The following is a description of a gene set: species: Mus musculus The progression of muscle tissue over time, from its initial formation to its mature state. Muscle tissue is a contractile tissue made up of actin and myosin fibers. Mouse Gene Set: GOBP_MUSCLE_TISSUE_DEVELOPMENT, and this is the list of marker genes: Cdk5, Myl7, Srf, Foxn2, Nkx2-5, S100b, Mir669a-10, Gpx1, Ephb1, Tbx5, Dsp, Pax3, Bmp10, Nr2f2, Hivep3, Pitx1, S1pr1, Pou4f1, Vgll4, Creb1, Lox, Pak1, Mir675, Bin3, Egln1, Ddx39b, Gata6, Zfp418, Ctdp1, Pdlim5, Itga8, Sema3c, Cntnap1, Speg, Cav1 (NCBI Gene Id 12389), Ccnt2, Pin1rt1, Wnt2, Adrb1, Pmp22, Mybpc3, Ttn, Smad4, Alpk3, Fgfr2, Fes, Barx2, Nrg1, Agtr2 (angiotensin II receptor, type 2), Jarid2, Fadd, Adamts9, Tsc1, Gata4, Gpcpd1, Boc, Mylpf, Hdac2, Srpk3, Rbm10, Ero1a, Ppp3ca, Parp2, Myoz1, Isl1, Ube4b, Twist1, Igf1, Myc, Gm2990, Angpt1, Vegfa, Megf10, Tbx2, Nkx2-6, Snw1, Nrap, Rara, Vax1, Adprhl1, Yap1, Hlx, Myod1, Dll1, Maml1, Mir669a-6, Fgf20, Bves, Hspa8, Col19a1, Eya1, Cops2, Hottip, Scx, Usp2, Zbtb18, Rgs2, Xirp1, Mbd2, 2810429I04Rik, Cited2, Maff, Fgf2, Sorbs2, Foxp1, Pdgfrb, Mir669a-8, Lncpint, Uqcc2, Itgb1, Shh, Klk1b1 (kallikrein 1-related peptidase b1), Tnn, Fosl2, Usp19, Kat2a, Myoz2, Klhl40, Zfp689, Nr3c1, Ddx17, Calr, Myh7, Vamp5, Tafazzin, Kcnk2, Cav3, Ankrd33, Hamp, Trip10, Gpc1, Gata5, Aldh1a2, Yy1, Bmp7, Xk, Rhoa, Dipk2a, Stra6, Fdps, Adrb2, Emd, Hsd17b1, Synb, Hey2, Dmrta2, Smad7, Tenm4, Tgfb2, Greb1l, Prox1 (NCBI Gene Id 320240), Bvht, Col11a1, Myl6, Pim1, Mir208a, Ndufv2, Rcan1, Rxra, Ccnd2, Phox2b, Ly6e, Hoxd9, Fhod3, Ski, Klhl41, Bmp5, Sgcb, Acvr1, Sav1, Egr2, Heg1, Sox6, Arid2, Tpm1, Ryr2, Heyl, Gm34220, Mir143, Dicer1, Sgcg, Mapk1, Ncam1, Vgll2, Crhr2, Ppif, Cby1, Asb2, Large1, Arrb2, Rxrb, Bcl9, Chd7, Rgs4, Rpl3l, Bmp4, Cdon (cell adhesion molecule-related/down-regulated by oncogenes), Prkg1, Tbx3, Fgf3, Ctcf, Acta1, Mbnl1, Eln, Klf5, Popdc3, Gtf3c5, Mir669a-3, Tbx18, Tcf7l2, Nprl3, Selenon, Mir669a-5, Cdc42, Myh10, Efnb2, Bmpr2 (NCBI Gene Id 98751), Foxp2, Ankrd1, Zfpm2, Fktn, Gja5, Svil, Mir669a-7, Bdnf, Wnt10b, Hamp2, Stac3, Col3a1, Pi16, Pten, Mtor, Ankrd2, Myh11, Actn2, Prkar1a, Fgf1, Grem1, Tnnc1, Rb1, Tnni1, Atg5, Hdac3, Abl1, Cenpf, Foxc1, Hand2, Kat8, Atg7, Nf1, Med1 (mediator complex subunit 1), Rbpj, G6pd2, Cyp26b1, Smyd1, Csrp2, Chrnd, Ryr1, Slc8a1, Met, Wt1, Pkp2, Camk2d, Flnb, Hspg2, Tnni3, Asnsd1, Col14a1, Tgfbr3, Jph2, Fgfr1 (fibroblast growth factor receptor 1), Tgfb1, Mesp1, G6pdx, Shox2, Actc1, Msc, Mstn, Six1, Lemd3, Tll2, Id2, Zmpste24, Gsk3a, Mef2c, Hey1, Myf6, Nfix, Norad, Psma6, Mir669a-1, Tnnt2, Rtl1, Zic3, Prkaa1, Mecp2, Irx3, Rbm24, Foxl2, Rbfox1 (NCBI Gene Id 58862), Efemp2, Atf3, Pgm5, Egr1, Nr1d2, Ang2, Tgfbr2, Prmt1, Frs2, Skil, Nog, Med20, Ednra, Neurl1a, Dlg1, Myl2, Ppp3cb, Nr4a1, Tbx20, Lmna, Bmal1, Myhas (myosin heavy chain gene antisense RNA), Csrp1, Myh6, Sirt6, Gli1, Rbp4, P2rx2, Cacybp, Agt, Tbx1, Mir133a-1, Pitx2, Nox4, Bmp2, Dyrk1a, Myocd, Sox9, Myom1, Osr1, Epo, Chrna1 (NCBI Gene Id 99038), Mir214, Sirt2, Pln, Fbxo22, Ptcd2 (pentatricopeptide repeat domain 2), Bcl9l, Myl6b, Hlf, Akirin1, Acadm, Btg2, Spg11, Myf5, Dll4, Sgcd, Tiparp, Casp8, Mapk14, Hand1, Ift88, Nln, Epor, Nebl, Sirt1, Slc25a4, Mettl21c, Smad1, Rarb, Lrp6, Plec, Mylk, Edn1, Sox15, Nfatc3, Hdac5, Hdac9 (histone deacetylase 9), Dner, Erbb4, Meg3, Mcub, Sox8, Kcnj8, Hmg20b, Sap30, Bmpr1a, Dmd, Slc9a1 (solute carrier family 9 (sodium/hydrogen exchanger), member 1), Zfpm1, Mbd3, Tshz3, Pkd2, Lmod3, Pdgfra (platelet derived growth factor receptor, alpha polypeptide), Fzd7, Smad3, T, Mylk3, Map2k4, Eya2, Mir145a, Mir669a-4, Gsk3b, Smo, Hoxd10, Vps54, Erbb3, Adra1b, Xirp2 (NCBI Gene Id 98983), Fhl2, Mettl8, Zfp950, Pdlim3, Sgcz, Kcnj11, Ep300, Fos, B4galnt2, Ift20, Cntnap2, Myh14, Ddx5, Ccn4, Flot1, Wnt3a, Myl3, Pin1, Eomes, Myog, Mapk11, Gjc1, Csrp3, Lemd2, Mrtfb, Lef1, 3425401B19Rik, Mtm1, Mir133a-2, Plagl1, Foxc2 (NCBI Gene Id 14234), Adra1a, Actn3, Hdac7, Homer1, Tfap2b, Tgfbr1, Ccnb1, Hnrnpu, Sin3b, Bcl2, Sik1, Nupr1, Nras, Rps6kb1, Ppara, Casq1, Myo18b, Vrk3, Cacna1s, Eng, Cripto, Mir1a-2, Akap6, Kdm6b, Abcc9, Ybx3, Igfbp5, Six4, Fgf8, Popdc2 (NCBI Gene Id 64082), Naglu, Ihh, Cflar, Snhg15, Schip1, Lrp2, Meis1, Hmgcr, Prickle1, Trp73, Igf2, Tcf21, Fkbp1a, Gja1, Apc, Trex1, Pax7, Fgf9, Cfl2, Ifrd1, Ctnnb1, Hdac4, Alpk2, Ccm2l, Ptch1, Tcap, Poglut1, AW551984, Mef2d, Luc7l, Sox11, Nphs1, Cavin4, Tomm70a, Mir669a-9, Myorg, Dsg2, Akap13, Neb, Notch1, Mef2a, Kras, Fkrp, Cxadr, Dkk1, Pax5, Col6a1, Ldha, Cdk1, Kel, Arid1a, Lrrc10, Mir669a-2, Ppp1r13l, Foxh1, Zfand5, Meox2, Cav2, Mylk2, Npr2